Given this list of marker genes WNT4, HNF1B, KIT, EGLN2, SIX1, REN, HNF4A, SFRP1, RSPO1, FGF7, NPHS1, TSHZ3, SMAD5, TLX1, TBX18, WNT5A, PDGFRB, EPO, FAT4, PECAM1, AXIN2, NPHS2, PAX2, DACT1, OSR1, KDR, HNF1A, DCN, TNC, WT1, PBX1, GDNF, KCTD1, AP2B1, VSX2, EMX2, EYA1, NTN1, ALDH1A2, ACTA2, EGLN3, FOXD1 (NCBI Gene Id 2297), NOTCH1 (NCBI Gene Id 54781), SALL1, RSPO3, EGLN1, SMAD1, BMP7, SIX2, LHX1, NOTCH2, BMP4, CITED1, TCF21, FGF8, NT5E, JAG1, DES, here is a description of the gene set: Markers of kidney cell lineage species: Homo sapiens Human Gene Set: WP_MARKERS_OF_KIDNEY_CELL_LINEAGE